The following is a description of a gene set: Binding to a lipid. studied in species Homo sapiens Human Gene Set: GOMF_LIPID_BINDING, and this is the list of marker genes: CAMP, LYN, APOF, TMEM199, PLEKHA8P1, VPS36, MAP1LC3A, ACOXL, SYT7 (NCBI Gene Id 9066), HCN1, SHBG, SAP30L, PLA2G2F, HGS, ATP13A2, ALOX15, RUFY4, PAQR6, ARHGEF5, TIRAP, SYT8, DNM1L, NFE2L1, SESTD1, SNX8, PFN3, SNX16, OSBPL8, CHMP4A, ATP5PO, PLAAT3, IAPP, CDIPT, STARD8, CYP4F11, SNX3, SCIN, SNX15, WDPCP, PMP2, CYP26B1, IQGAP2, CIDEC, PLA2G4F, FRMPD2, SNX13, BCAS3, GPAA1, PRKCI, PSD, CYP26A1, SOAT1, MYO1E, MARK1, PIK3C2G, PITPNB, FRMPD4, APOD, STARD9, OSBP2, P2RX7, DROSHA, FLII, PXDC1, OSBPL10, DEFB106B, SYT11 (NCBI Gene Id 92303), DEFB118, BAIAP3, CPNE6 (copine 6), PEBP1, AP2M1, PLA2G15, BIN2, BIN1, FGD2, RPE65, DEFB119, CD81, SNX6, GSDMD, ATP1A2, ACOX3, STARD7, SERPINA6, PCYT1A, KIF16B, DEFB106A, TIMD4, PLEKHA1, BSCL2 (NCBI Gene Id 84753), FABP4, OSBPL9, DBT, RCSD1, PITPNM2 (phosphatidylinositol transfer protein membrane associated 2), CARMIL2 (NCBI Gene Id 146206), LAPTM4B, HIP1R, PIGT, APOL1, SCARB2, MYO10, C2CD2L, CYP2W1, MANF, CPNE9, DEFB107A, BLTP2, RAG2, MCOLN1, TULP1, SH3GL3, CAV1, OPN5, BAIAP2L2, SHC1, H2BC11, CADPS, SH3GL2, LTC4S, GOLPH3L, TOM1, FFAR4, PLA2G4B, OSBPL2, CIBAR1, APOL6, VAMP2, FCGR3B, SCARB1, RORA, S1PR2, SEC14L3, CRABP1, OSBPL7, LPAR4, PFN1, TTPA, OGT, DEFB107B, NR5A2, BPIFC, CHPT1, RUFY1, CPNE2, OTC, SPHK1, PLA2G2C, ANXA2, BPIFA3, KCNJ3, MVB12A, SNX18, FABP6, PNPLA3 (patatin like phospholipase domain containing 3), STARD4, SPTBN4, PSMA1, S100A8, ADORA2A, GSN, TLR6, LCN12, SULT2B1, TNS2, CD4, SGIP1, RASGRP2, PIK3C2B, TOM1L1, SYT9, RPS6KC1, TWF2, AR, RASGRP3, UGT1A6, SYT6, FUZ, AIDA (axin interactor, dorsalization associated), PPP5C, TOM1L2, PITPNM1, MAPKAP1, CD1D, GSTM2, DAB2IP, ABCA4, SNX32, DNM1, MICALL1, TREM2, CD1C, BPIFB1, PPT1, UGT1A4, TLR1, SERPINA5, NCF1B, RNASE3, MAG, CD55 (NCBI Gene Id 1604), NPC1, ADAP2, RPH3A, GRAMD1B, RACGAP1, MBP, IL2, SDCBP2, PDZD8, FNBP1, CPNE7, TPCN2, PGRMC2, HSPA2, OMA1, NR1H4, SH3YL1, PPARD, GLTP, PLEKHB2, SCAP, APOA5, CHMP2A, PLA2G1B, OSBPL6, ADGRB1, LAMA1, PIGK, TLR10, PLA2G7, PACSIN2, AXL, GLE1, PON1, EXOC8, ATP5MC2, PLEKHA2, PSMB4, MREG, CYTH4, NR5A1, AMER3, UGT2B4, FFAR3, APPL2, ARAP2, VCP, PLA2G2A (NCBI Gene Id 5320), BPIFB2, PIRT, RORC, MTTP, LIPF, S1PR3, SH3GL1, MELK, STAP1, ACOX2, SYT2, NINJ2, PTAFR, PAQR9, ALDH1A2, UNC13A, CFL1, TSPO, MAP1LC3C, SYTL4 (synaptotagmin like 4), EPN2, SYT4, KCNJ2, FABP12, SLC9A1, DEFB136, CD14, ERLIN1, UGT2B17 (UDP glucuronosyltransferase family 2 member B17), GABARAPL1, CD1E, TWF1, VILL, SNX10, STX3, BPIFB6, JCHAIN, WDFY3, APOA4, ZFYVE16 (zinc finger FYVE-type containing 16), SNX25, CLN8, PTCH1, LDLRAP1, PRAP1, ZCCHC2, CLEC4E, TEC, ESRRB, SNX1, C2CD5, PSAP, KCNQ1, CPTP, APOE, ITPR2, RXRA, SNX9 (sorting nexin 9), PLCZ1, APOC3, BAD, CALB1, EPHX1, ANXA5, AMER2, LPAR2 (lysophosphatidic acid receptor 2), PPARA, GGA1, PICK1, KCNJ1, PASK, PTGDS, SH3PXD2B, SYT16, BPIFA2, ITPR1, ESYT1, STRA6, NME4, GPR183, ESRRG, SLC9A3, ESRRA, GABARAP, VIL1, GSDMB, INSIG2, ANXA10, PITPNA, GBF1, PACSIN3, SIDT1, CLIP3, DOC2A, MAP1LC3B2, ALOX5AP, DGKG, ACBD4, ZCCHC14, FAAH, ACADVL, ARAP1, STOML2, PRKCA, ANXA4, PHLDA2, ID3, EXOC1, CLVS2, ANXA2P2 (NCBI Gene Id 304), DCD, PITPNM3, ING2, CPNE5, DMBT1, TRIP10, SNX29, TRAF2, SNX17, GSDME, SYT10, ALB, UNC13B, PHLDA3, FES, STAM2, IRX5, SYTL3, FABP1, SYT13, PLA2G4E, PLEKHA3 (pleckstrin homology domain containing A3), UGT2B15, PLTP, OPA1, SYT1 (synaptotagmin 1), RNASE7, SMPD3, ECI2, NLRP6, SH3PXD2A, GRAMD2A, PEX3, SVIL (supervillin), JAG1, MTM1, LPAR3, PARD3, UGT1A8, GSDMA, PTEN, ADH7, FIS1, CLN3, PFN4, OSBPL3, COQ8B, CD300A, CGAS, S100A10, AKR1D1 (NCBI Gene Id 6718), PLA2G10, PAQR7, PGR, ZFYVE9, UNC119, VPS13B, RASGRP4, CASP4, LAMB1, RBP4, ABCG1, SNX30, GCDH, GPR141, CD300LF, PLEKHA4, TARDBP, HAVCR1, NPC2, TULP3, HNF4A, SNAP91, STAM, STARD10, NRGN, GPR31, PLEKHA8 (pleckstrin homology domain containing A8), UNC13C, NCF4, OPN3, CD1B, OBSCN (obscurin, cytoskeletal calmodulin and titin-interacting RhoGEF), UCP1, ANXA9, FNBP1L (NCBI Gene Id 54874), FITM2, ATG2B, PLA2G2D, FCHSD1, ULBP2, ATP1A3, MCF2L, HSD11B1, CRABP2, FABP5P3, CYTH3, RAB35, LTF (NCBI Gene Id 4057), IQSEC1, EPN1, COQ9, TPCN1, PREX1, STARD3, SNX11, GSTA1, SNF8, TECPR1, WIPI1, APPL1, TWNK, RBP2, PSD2, MTSS2, TRPM3, SPTBN2, ARAP3, PARD3B, CHMP3, RTN4R, SBF2, FITM1, ATP5MC3, STARD6, NR1H3, SOAT2, F2, GRB7, SYT17, ANXA13, ARL6, OSBPL11, OPN4, IGHM, DOK7, IGF2R, BPIFB3, ARHGAP32, WASHC2C, EPB41, CYP3A4, PLEKHN1, FCHSD2, GBP1, PHB2, S1PR4, PITPNC1, PAQR8, GAS6, TRIM72, PROM2, NINJ1, SEC14L2, PACSIN1, PLCB1, UGT1A7, TLR2, HSPD1 (heat shock protein family D (Hsp60) member 1), SYT12, AMER1, RASAL1, GSDMC, SNX5, ESYT2, ACBD5, SNX4, NISCH, MCTP2, ZFYVE19, KL, IQGAP1, PIGU, BPI, ARFIP2, SNCA, ATP8B1, ESR2, CPS1, STARD5, TSPO2, ANKFY1, CYP27C1, CD36, EPN3, HCK, SMO, UGT1A9, GABARAPL2 (GABA type A receptor associated protein like 2), NR3C2, ACBD3, ACBD6, GGA3, RBP5, MFGE8 (milk fat globule EGF and factor V/VIII domain containing), ANXA11, APOA2, SNX19, DGKD, SYT15, PHF12, AMPH, VDAC2, F10, GRAMD1A, ZRANB2, EXOC7, GSTP1, DYSF, NF1, TRIL, IRGM, GAS1, ARHGAP33, MYO1B, PPARG, ACOT7, NLRP3, SCP2, TTPAL (NCBI Gene Id 79183), ARHGAP44, APOL4, NR3C1, VDR, ACOT12, OSBPL1A, SEPTIN12, GAP43 (growth associated protein 43), RS1, ADH4, GLTPD2, TLN1, DENND1A, BTK, NUP62, UGT1A1, UNC119B, MAPT, TRPV1, CLN6, RAPGEF6, FABP3, TLR4, WASHC2A, SPART, ZFYVE26, INSIG1, PLA2G2E, SLC38A9, CETP, ARFIP1, NUMA1, SYTL2, PLA2G5, TEX2, SULT1E1, PGRMC1, NR2F2, MVB12B, GPR155, SNX7, HMGB1, PRR7, MCTP1, NUP35, PCYT1B, HIP1, AP2A2, FYB1, STARD3NL, ZFYVE1, SPRR2A, CADPS2, CPNE3, APOB, WNT5A, APOL3, LANCL2, BIN3, GOLPH3, RBP7, NCF1C, ITPR3, HDLBP, AKT1, CD1A, SYT5, MME, GRK5, PLEK2, FZD5, CYP26C1, VEPH1, S100A9, GC, ACOT11, ABCA1, ACBD7, SNX14, CYTH2, PCLO, GHR, VDAC1, INTU, BAX, RBP1, SYT14, SPTBN1, NDUFAB1, RUBCNL (rubicon like autophagy enhancer), JPH2, F3, EPDR1 (NCBI Gene Id 96010), DGKB, ATP1A1, APOC1, C8G, OC90, FERMT2, ATP5MC1, MYO1G, AVIL, SCUBE2, ESR1, WDFY1, EEA1, DEFB4A, THBS1, FERMT3, GGA2, SELL, CERKL, SELP, CIDEA, MTSS1, APOC2, APOH, MITD1, STAR, ANXA8L1, SDCBP, HSD11B2, RLBP1, PAFAH2, TIAM1, CD6, RUBCN, PLA2G4C, S100G, OSBPL5 (NCBI Gene Id 57656), SMURF1, DAPP1, SPON2, DGKA, ADH5, SNX21, FABP2, CLVS1, GPER1, CIDEB, MARK2, BPIFA1, C8orf44-SGK3, ESYT3, ANXA1, PLCD1, GPIHBP1 (glycosylphosphatidylinositol anchored high density lipoprotein binding protein 1, NCBI Gene Id 338328), ZFYVE28, ANXA7, RARA, NSFL1C, RASA4B, NPC1L1, MAP1LC3B, ANXA8, SYTL5, CEACAM5, KRIT1, PLEKHF1, WDR45, GPR119, TMEM97, PLD1, PRLR, RNASE2, FCHO2, CLINT1, RHO, DNM2, TNFAIP8L3, PLIN1, DBI, OSBP (NCBI Gene Id 5007), CAPG, RASA2, FABP9, GRAMD1C, ALOX15B, CPNE8, ANXA3, LY96 (NCBI Gene Id 23643), MCOLN3, MAL, FABP5, PCTP, DPEP1, LPAR1, ADAP1, LBP, PLEKHA5, NGF, SH3GLB1, BLNK, FZD7, PLD2, PIK3C2A, DOC2B, NOXO1, LRAT, UGT2B7, ACOX1, CYTH1, SNX12, FFAR1, ANXA6, MYOF (NCBI Gene Id 26509), ARHGAP35, PLA2G4D, SGK3, SNX31, PXK, RNF34, DLC1, UGT1A10, WDR45B (NCBI Gene Id 56270), DENND1B, GAB2, UGT1A3, STARD13, PROM1, ENTHD1, NCF1, PRAM1, OXER1, SNX27, PLEKHF2, S1PR1, PAQR5, MYCBPAP, UQCC3, SNX24, RBSN (rabenosyn, RAB effector), ACTN2, APOLD1, RASGRP1, S100A13, DENND1C, PHLDA1, OPHN1, HS1BP3, SNX22, COMMD1, NR4A1, CPNE4, SNX2, PFN2, APOL5, RBP3 (retinol binding protein 3), RASA4, SNX33, TRPV4 (NCBI Gene Id 8098), ARHGAP26, KCNH1, PDIA2, ERLIN2, FUNDC2, TPP1, ATG2A, SYT3, SYP, MAP1B, CCDC88A, DEPTOR, PLCB2, SNX20, FER, CERT1, SYT14P1, CDK5R2 (cyclin dependent kinase 5 regulatory subunit 2), FABP7, APOL2, AGAP1, GPR12, CYP21A2, DEFB114, PICALM, TMEM175, HSD17B1, BBS5, SEC14L4, THY1, PLA2G4A, CPNE1, ARHGAP9, FFAR2, APOM, GABARAPL3, CAVIN2, APOA1, WIPI2, CYP2R1, SNAP25, BPIFB4, SPATA18, PSD4, RAPGEF2, MINAR2